Given this list of marker genes SETBP1, ATRX, KDM6B, SMARCA2, SNIP1, KCNH1, CDK19, NSUN2, HECW2, SETD1A, TRIO, SRCAP, DVL1, GALNS, SOX4, H4C5, PIGL, TMEM70, TALDO1 (NCBI Gene Id 6888), TRRAP, WDR26, STAG1, SLC6A1, KLHL15, TCF4, HS2ST1, CUL4B, IRX5, RNF113A, MYT1L, HNRNPH2, POLR1C, FKBP6, SOS1, HECTD4, TCOF1, EXOSC5, DHCR7, NXN, RALGAPA1, ASXL3, RNU4-2, GATAD2B, CLIP2, ATP6V1B2, MKS1, DPYSL5, IDUA, UBE3A, WAC, POLR1B, KCNK4, PIGN, LARP7 (NCBI Gene Id 51574), SET, ZMIZ1, ERLIN2, SMARCC2, MAP3K7, BUD23, TASP1 (NCBI Gene Id 55617), MTOR, ATPAF2, PRPS1, ATIC, MBD5, ZNF526, ACTL6B, CD96 (NCBI Gene Id 337949), HUWE1, H3-3A, HDAC6, PACS2, ARID1B, KAT5, TMEM270, AP4B1, GNS, CDC42, QRICH1, ADSL, ANKRD11, STX1A, MGAT2, RNF2, MAP2K1 (mitogen-activated protein kinase kinase 1), GTF2I, SEC23A, LIG4, GPC3, GTF2IRD2, GLB1, KATNB1, POGZ (pogo transposable element derived with ZNF domain), KCNMA1, SMARCE1, NR2F1, CNTNAP2, INSR, ADAT3, ZMYND11, MAPK1, NCF1 (neutrophil cytosolic factor 1), NEXMIF, OCA2, DYM, TRPM3, ATP10A, NALCN, AP2M1, SPEN, FAM20C, PTDSS1, NMNAT1, MED13, PPM1D, METTL27, GNB2, ZSWIM6, PGAP2, TMCO1, AHDC1, SKIC3, INTS11, CENPF, KIF15, POLA1, PIGB, CHD2, ADAMTSL2, RNF125, RNU12, KCNJ8 (NCBI Gene Id 3764), B3GLCT, MED12 (mediator complex subunit 12), H4C11, LIMK1, TRIP12, GNPTAB, SLC12A2, SPRED2, TBL2, BRPF1, SLC2A1, ZNF699, PIK3CA, GTF2IRD1 (NCBI Gene Id 9569), SMARCA4, SSR4, ZNF148, WLS, ACTG1, UBE2A, ROR2, AP4E1, DPYD, TMEM147, CAMK2A, PACS1, NONO, SH3PXD2B, TMEM67, SF3B2, ADNP, RAI1, NRXN1, FLCN, SNRPN (small nuclear ribonucleoprotein polypeptide N), ALG9, ELN, RAF1, FOXP2, SMARCB1, VPS37D (NCBI Gene Id 171020), AUTS2, H4C3, STRADA, RFC2, CDC42BPB, KMT2B, DPF2, AGA, PIGU, SMARCD1, ZFX, SYNGAP1, CCDC47, PMM2, AP1S2, SCN1A, WDR4, RPS6KA3, AP4M1, GPC4, POLR1D, WDR73, ARID2, EIF4H, KCNN3, PSPH, SF3B4, DDB1, ARID1A (NCBI Gene Id 8289), DNAJC30, DACT1, KAT6A, AP4S1, FBXO11, MED13L, KDM3B, ABCC9, SALL1, UBE3B, DDX11, ACTB, BAZ1B, TWIST2, AFF3, MIPEP, PGAP1, KIF7, SOX11, LZTR1, THUMPD1, IFT140, here is a description of the gene set: studied in species Homo sapiens Wide mouth Human Gene Set: HP_WIDE_MOUTH Distance between the oral commissures more than 2 SD above the mean. Alternatively, an apparently increased width of the oral aperture (subjective).